The following is a description of a gene set: species: Homo sapiens The series of molecular signals initiated by the binding of a ligand to a beta-type platelet-derived growth factor receptor (PDGFbeta) on the surface of a signal-receiving cell, and ending with the regulation of a downstream cellular process, e.g. transcription. Human Gene Set: GOBP_PLATELET_DERIVED_GROWTH_FACTOR_RECEPTOR_BETA_SIGNALING_PATHWAY, and this is the list of marker genes: HIP1, HIP1R, CLASP2, PDGFA, PDGFB, PDGFRL, SRC, PTPN12, LRP1, PDGFRB, LOX (NCBI Gene Id 4015), MYOCD, PTPN1, PTPN2, ABL1